Given this list of marker genes OTULIN, RBCK1, NSMAF, RIPK1, BIRC2, SPATA2, XIAP, ADAM17, UBE2D1, USP4, OPTN, FADD, BAG4, STUB1, OTUD1, MAPKAPK2, SPPL2B, CHUK, TNFAIP3, SMPD2, UBE2D3, UL36, TRAF2, SMPD3, IKBKB, SPPL2A, USP21, TAB2 (TGF-beta activated kinase 1 (MAP3K7) binding protein 2), TRADD, MIB2, OTUD7B, CFLAR, CLIP3, TBK1, TRAF1, SHARPIN, RACK1, UBB, UBC, UBE2D2, TNFRSF1A, TNF, BIRC3, CYLD, USP2, TAX1BP1, MAP3K7, IKBKG, RPS27A, OPG199, RNF31, UBA52 (NCBI Gene Id 7311), TAB3, IKBKE, CASP8, TAB1, UBE2L3, MADD, ULK1, here is a description of the gene set: Reactome Pathway: TNF signaling studied in species Homo sapiens part of: Death Receptor Signaling The inflammatory cytokine tumor necrosis factor alpha (TNF-α) is expressed in immune and nonimmune cell types including macrophages, T cells, mast cells, granulocytes, natural killer (NK) cells, fibroblasts, neurons, keratinocytes and smooth muscle cells as a response to tissue injury or upon immune responses to pathogenic stimuli (Köck A. et al. 1990; Dubravec DB et al. 1990; Walsh LJ et al. 1991; te Velde AA et al. 1990; Imaizumi T et al. 2000). TNF-α interacts with two receptors, namely TNF receptor 1 (TNFR1) and TNF receptor 2 (TNFR2). Activation of TNFR1 can trigger multiple signal transduction pathways inducing inflammation, proliferation, survival or cell death (Ward C et al. 1999; Micheau O and Tschopp J 2003; Widera D et al. 2006). Whether a TNF-α-stimulated cell will survive or die is dependent on autocrine/paracrine signals, and on the cellular context.<p>TNF binding to TNFR1 results initially in the formation of complex I that consists of TNFR1, TRADD (TNFR1-associated death domain), TRAF2 (TNF receptor associated factor-2), RIPK1 (receptor-interacting serin/threonine protein kinase 1), and E3 ubiquitin ligases BIRC2,BIRC3 (cIAP1/2,cellular inhibitor of apoptosis) and LUBAC (Micheau O and Tschopp J 2003). The conjugation of ubiquitin chains by BIRC2/3 and LUBAC (composed of HOIP, HOIL-1 and SHARPIN ) to RIPK1 allows further recruitment and activation of the TAK1 (also known as mitogen-activated protein kinase kinase kinase 7 (MAP3K7)) complex and IκB kinase (IKK) complex. TAK1 and IKK phosphorylate RIPK1 to limit its cytotoxic activity and activate both nuclear factor kappa‐light‐chain‐enhancer of activated B cells (NFkappaB) and mitogen‐activated protein (MAP) kinase signaling pathways promoting cell survival by induction of anti-apoptotic proteins such as BIRC, cellular FLICE (FADD-like IL-1β-converting enzyme)-like inhibitory protein (cFLIP) and secretion of pro-inflammatory cytokines (TNF and IL-6). When the survival pathway is inhibited, the TRADD:TRAF2:RIPK1 detaches from the membrane-bound TNFR1 signaling complex and recruits Fas-associated death domain-containing protein (FADD) and procaspase-8 (also known as complex II). Once recruited to FADD, multiple procaspase-8 molecules interact via their tandem death-effector domains (DED), thereby facilitating both proximity-induced dimerization and proteolytic cleavage of procaspase-8, which are required for initiation of apoptotic cell death (Hughes MA et al. 2009; Oberst A et al. 2010). When caspase activity is inhibited under certain pathophysiological conditions (e.g., expression of caspase-8 inhibitory proteins such as CrmA and vICA after infection with cowpox virus or CMV) or by pharmacological agents, deubiquitinated RIPK1 is physically and functionally engaged by its homolog RIPK3 leading to formation of the necrosome, a necroptosis-inducing complex consisting of RIPK1 and RIPK3 (Tewari M & Dixit VM 1995; Fliss PM & Brune W 2012; Sawai H 2013; Moquin DM et al. 2013; Kalai M et al. 2002; Cho YS et al. 2009, He S et al. 2009, Zhang DW et al., 2009). Within the complex II procaspase-8 can also form heterodimers with cFLIP isoforms, FLIP long (L) and FLIP short (S), which are encoded by the NFkappaB target gene CFLAR (Irmler M et al. 1997; Boatright KM et al. 2004; Yu JW et al. 2009; Pop C et al. 2011). FLIP(S) appears to act purely as an antagonist of caspase-8 activity blocking apoptotic but promoting necroptotic cell death. The regulatory function of FLIP(L) has been found to differ depending on its expression levels. FLIP(L) was shown to inhibit death receptor (DR)-mediated apoptosis only when expressed at high levels, while low cell levels of FLIP(L) enhanced DR signaling to apoptosis (Boatright KM et al. 2004; Okano H et al. 2003; Yerbes R et al. 2011; Yu JW et al. 2009; Hughes MA et al. 2016). In addition, caspase-8:FLIP(L) heterodimer activity within the TRADD:TRAF2:RIPK1:FADD:CASP8:FLIP(L) complex allowed cleavage of RIPK1 to cause the dissociation of the TRADD:TRAF2:RIP1:FADD:CASP8, thereby inhibiting RIPK1-mediated necroptosis. TNF-α can also activate sphingomyelinase (SMASE, such as SMPD2,3) proteins to catalyze hydrolysis of sphingomyeline into ceramide (Adam D et al.1996; Adam-Klages S et al. 1998; Ségui B et al. 2001). Activation of neutral SMPD2,3 leads to an accumulation of ceramide at the cell surface and has proinflammatory effects. However, TNF can also activate the pro-apoptotic acidic SMASE via caspase-8 mediated activation of caspase-7 which in turn proteolytically cleaves and activates the 72kDa pro-A-SMase form (Edelmann B et al. 2011). Ceramide induces anti-proliferative and pro-apoptotic responses. Further, ceramide can be converted by ceramidase into sphingosine, which in turn is phosphorylated by sphingosine kinase into sphingosine-1-phosphate (S1P). S1P exerts the opposite biological effects to ceramide by activating cytoprotective signaling to promote cell growth counteracting the apoptotic stimuli (Cuvillier O et al. 1996). Thus, TNF-α-induced TNFR1 activation leads to divergent intracellular signaling networks with extensive cross-talk between the pro-apoptotic/necroptotic pathway, and the other NFkappaB, and MAPK pathways providing highly specific cell responses initiated by various types of stimuli.